Given this list of marker genes GRK2 (NCBI Gene Id 156), ZC3H12A, ATP2A1, MIR30E, SRI, BIN1, ADCY10, ATP1A2, PIK3CG, here is a description of the gene set: studied in species Homo sapiens Human Gene Set: GOBP_NEGATIVE_REGULATION_OF_STRIATED_MUSCLE_CONTRACTION Any process that stops, prevents, or reduces the frequency, rate or extent of striated muscle contraction.